The following is a description of a gene set: species: Homo sapiens Human Gene Set: GOBP_L_AMINO_ACID_CATABOLIC_PROCESS The chemical reactions and pathways resulting in the breakdown of an L-amino acid., and this is the list of marker genes: SHMT1, DDAH1 (NCBI Gene Id 23576), CARNS1, GLS2, KYNU, ALDH4A1, CARNMT1, GLUL, GPT2, ATP2B4, ACMSD, PIPOX, AGXT2, GLS, HDC, PRODH2, SDSL, IVD, GPT, HGD, AFMID, GAD1, GAD2, MIR21, TDO2, AMDHD1, DAO (NCBI Gene Id 1610), CSAD, ENSG00000274276, SDS, QDPR, TAT, IDO1, CDO1, AADAT, KYAT3, ARHGAP11B, MAT1A, GOT1, OAT, DLST, NOS1, AUH, NOS2 (NCBI Gene Id 4843), FAH, ARG1, GCAT, HAL, HPD, RIDA, HMGCL, ASRGL1, IDO2, FTCD, GOT2, BCKDK, UROC1, MCCC2, HAAO, HNMT, KMO, CBS, MCCC1, HMGCLL1 (NCBI Gene Id 54511), PRODH, AASS, KYAT1, PAH, IL4I1, DDO, GLUD2, ADHFE1, ALDH8A1, NOS3, AGXT, GLUD1, ARG2, GSTZ1